Given this list of marker genes Atp2a2, Ube3a, Qrich1, Cdkal1, Car10, Mbnl1, Lrrc4, Ywhab, Setd5, Tsr2, Cdh6, Rgs7bp, Msl1, Gkap1, Naa50, Fgf4, Mcf2, Il1rap, Stt3b, Ccdc38, Rab2b, Stag2, Prl2a1, Dnaja2, Dpy19l3, Copb1, Cdr2, Trim9, Ano4, Apoo, Tmem65, Cdk17, Gpr150, Dag1, Slc9a6, Sec22c (SEC22 homolog C, vesicle trafficking protein), Rtl4, Tes (NCBI Gene Id 52121), Smarcad1, Homer1, Arcn1, Col4a1, Epcip, Icmt, Cxcl13, Qser1, Bmt2, Abcc1 (ATP-binding cassette, sub-family C member 1), Adgrg6, Map3k1, Prps1l1, Tram1, Plcl1, Gtf2i, Runx3, Brwd3, Ide, Epm2aip1, Pdzrn3, Zdhhc16, Ube2d2b, Zdhhc15, Slc4a7, Ppp1r3a, Cbfb, Acer3, H2-Q7, Pou3f4, Pcdh8, Lpp, Sec11a, Ppp2r3d, Dph3, Spag9, Galr1, Ndel1, Ctbp2, Fbxo21, Rai2, 2610528J11Rik, Hpgds, Slc30a4, Tbc1d31, Slc12a6, Kdm7a, Cltc, Golm2 (NCBI Gene Id 319996), Ppp3r1, Cd200r4, Tmem167, Tafa2, St6gal2, Psmd1, Slc25a36, Klf4, Cul5, Kics2, Rc3h1, Mylk, Rasa1, Plekhm3, Man2a1, Pcsk2, Pcgf3, Slc7a14, Ebf1, Slc25a30 (NCBI Gene Id 67554), Ibsp, Rwdd4a, Otud4, Gzf1, Ap1ar (adaptor-related protein complex 1 associated regulatory protein), Unc119b, Mmp1a, Mtpap, Bend7, Per2, Tmem45a2, Fign, Fam120c, Hsd17b13, Zbtb18, Scn3a, Pdzd8, Slc26a3, H3f3b, Tmf1, Eloc, Mbnl2, Grm4, Rab30, Xirp2, Prrc2b, Pcdh20, Tmod2, Dennd6a, Miga1, Ret, Cnn2, Cadm2, Csrnp3, Samd5, Ercc6l, D630023F18Rik, Sacm1l, here is a description of the gene set: from publication Chen Y, Wang X (PMID 31504780) Mouse Gene Set: MIR_7043_5P Genes predicted to be targets of miRBase v22 microRNA mmu_miR_7043_5p in miRDB v6.0 with MirTarget v4 prediction scores > 80 (high confidence targets). studied in species Mus musculus